Given this list of marker genes SHC1, CRKL, PIK3CD, JAK1, UBA52, PIK3R2, JAK3, UBC, BLNK, IL2RA, PRKACA, STAT5B, PIK3CA, PIK3CB, IL2RB, PIK3R3, TEC, SOS1, IL2RG, IL3, GAB2, RPS27A, HCK, STAT5A, INPPL1, IL5RA, YES1, IL3RA, PTPN11, RAPGEF1, SYK, CRK, VAV1, CSF2RB, GRB2, FYN, CSF2, PTPN6, CBL, IL2, INPP5D, PIK3R1, UBB, JAK2, LYN, CSF2RA (colony stimulating factor 2 receptor subunit alpha), IL5, YWHAZ, here is a description of the gene set: species: Homo sapiens Reactome Pathway: Interleukin-3, Interleukin-5 and GM-CSF signaling part of: Signaling by Interleukins The Interleukin-3 (IL-3), IL-5 and Granulocyte-macrophage colony stimulating factor (GM-CSF) receptors form a family of heterodimeric receptors that have specific alpha chains but share a common beta subunit, often referred to as the common beta (Bc). Both subunits contain extracellular conserved motifs typical of the cytokine receptor superfamily. The cytoplasmic domains have limited similarity with other cytokine receptors and lack detectable catalytic domains such as tyrosine kinase domains.<br><br> IL-3 is a 20-26 kDa product of CD4+ T cells that acts on the most immature marrow progenitors. IL-3 is capable of inducing the growth and differentiation of multi-potential hematopoietic stem cells, neutrophils, eosinophils, megakaryocytes, macrophages, lymphoid and erythroid cells. IL-3 has been used to support the proliferation of murine cell lines with properties of multi-potential progenitors, immature myeloid as well as T and pre-B lymphoid cells. IL-5 is a hematopoietic growth factor responsible for the maturation and differentiation of eosinophils. It was originally defined as a T-cell-derived cytokine that triggers activated B cells for terminal differentiation into antibody-secreting plasma cells. It also promotes the generation of cytotoxic T-cells from thymocytes. IL-5 induces the expression of IL-2 receptors (Kouro & Takatsu 2009). GM-CSF is produced by cells (T-lymphocytes, tissue macrophages, endothelial cells, mast cells) found at sites of inflammatory responses. It stimulates the growth and development of progenitors of granulocytes and macrophages, and the production and maturation of dendritic cells. It stimulates myeloblast and monoblast differentiation, synergises with Epo in the proliferation of erythroid and megakaryocytic progenitor cells, acts as an autocrine mediator of growth for some types of acute myeloid leukemia, is a strong chemoattractant for neutrophils and eosinophils. It enhances the activity of neutrophils and macrophages. Under steady-state conditions GM-CSF is not essential for the production of myeloid cells, but it is required for the proper development of alveolar macrophages, otherwise, pulmonary alvelolar proteinosis (PAP) develops. A growing body of evidence suggests that GM-CSF plays a key role in emergency hematopoiesis (predominantly myelopoiesis) in response to infection, including the production of granulocytes and macrophages in the bone marrow and their maintenance, survival, and functional activation at sites of injury or insult.<br><br> All three receptors have alpha chains that bind their specific ligands with low affinity (de Groot et al. 1998). Bc then associates with the alpha chain forming a high affinity receptor, though the in vivo receptor is likely be a higher order multimer as recently demonstrated for the GM-CSF receptor.<br><br> The receptor chains lack intrinsic kinase activity, instead they interact with and activate signaling kinases, notably Janus Kinase 2 (JAK2). These phosphorylate the common beta subunit, allowing recruitment of signaling molecules such as Shc, the phosphatidylinositol 3-kinases (PI3Ks), and the Signal Transducers and Activators of Transcription (STATs). The cytoplasmic domain of Bc has two distinct functional domains: the membrane proximal region mediates the induction of proliferation-associated genes such as c-myc, pim-1 and oncostatin M. This region binds multiple signal-transducing proteins including JAK2, STATs, c-Src and PI3 kinase. The membrane distal domain is required for cytokine-induced growth inhibition and is necessary for the viability of hematopoietic cells. This region interacts with signal-transducing proteins such as Shc and SHP and mediates the transcriptional activation of c-fos, c-jun, c-Raf and p70S6K.<br><br><br><br>Figure reproduced by permission from Macmillan Publishers Ltd: Leukemia, WL Blalock et al. 13:1109-1166, copyright 1999. Note that residue numbering in this diagram refers to the mature Common beta chain with signal peptide removed.